Given this list of marker genes Atp1b2, Kcne2, Kcnip2, Actn2, Myh6, Tnnt3, Atp2a3, Casq2, Kcnk6, Kcne5, Mybpc3, Myl1, Mylk, Fxyd2, Pde5a, Ces1d, Akap9, Atp1a2, Kcnk18, Calm3, Cald1, Lmod1 (leiomodin 1 (smooth muscle)), Ryr2, Tnnt1 (troponin T1, skeletal, slow), Atp2b3, Tnnt2, Itga1, Myh3, Stim1, Kcnj14, Itpr3, Myh8, Cacnb1, Atp2b4, Mme, Cacna2d2, Cacng6, Camk2g, Trdn (triadin), Vcl, Casq1, Cacng4 (NCBI Gene Id 54377), Nos1, Kcnk1, Itpr1, Prkaca, Ahcyl1, Kcnk2, Pxn, Kcnd3, Tcap, Acta1 (actin alpha 1, skeletal muscle), Slc8a2, Atp1a3, Tnni2, Calm2, Kcne3, Dmd, Myh11, Myl3, Mybpc1, Cacng7 (NCBI Gene Id 81904), Kcnk4, Atp1b1, Sri, Gucy1b2, Kcnk3, Gucy1a2, Fxyd1, Fxyd3 (FXYD domain-containing ion transport regulator 3), Kcnj12, Atp1a1, Mybpc2, Tln1 (talin 1), Cacna1c, Tpm2, Dmpk, Tmod1, Kcnk15 (potassium channel, subfamily K, member 15), Actc1, Pak2, Tnni1, Abcc9, Atp2b2, Camk2d, Atp2a1, Kcnd2, Fxyd6, Tmod4, Fkbp1b, Npr2, Npr1, Ryr1, Nppc, Itpr2, Actn3, Kcne4, Asph, Kcnd1, Pak1, Myl6b, Tpm4, Actg2, Pln, Myl6, Kcnip3, Sorbs1, Kcna5, Fxyd7, Sorbs3, Slc8a1, Kcnq1, Kcnk12, Atp2a2, Kcnk13, Myl9, Atp1a4, Cacnb2, Camk2a, Atp2b1 (NCBI Gene Id 67972), Corin, Tnnc1, Kcnk9, Trpc1, Kcnk5, Neb, Kcnj2, Tpm3, Kcnk7, Kcnj4, Myl12b, Myl4, Atp1b3 (ATPase, Na+/K+ transporting, beta 3 polypeptide), Tnni3, Des, Fxyd4, Kcnip4, Calm1, Myl10, Tmod3, Camk2b, Tpm1, Cacng8, Kcnk10, Tmod2, Nppa, Mylpf, Vim, Gucy1b1, Kcnip1, Tnnc2, Kcnk16, Kcnh2 (potassium voltage-gated channel, subfamily H (eag-related), member 2), Gucy1a1, Slc8a3, Myl2, Myl7, Acta2, Kcnj11, Ryr3, here is a description of the gene set: Muscle contraction Mouse Gene Set: REACTOME_MUSCLE_CONTRACTION species: Mus musculus